Given this list of marker genes Copb1, Copa, Arcn1, Golga5, Kdelr3, Copg1, Tmed3, Kdelr2, Tmem199, Tmed2, Copz1, Kdelr1, Dipk2a, Copz2, Copb2, Scyl1, Copg2, Cope, here is a description of the gene set: The lipid bilayer surrounding a COPI-coated vesicle. Mouse Gene Set: GOCC_COPI_COATED_VESICLE_MEMBRANE studied in species Mus musculus